Given this list of marker genes TRPC1, ATP2A2, SLC8A2, CORIN, GJA5, NKX2-5, ACE2, TBX5, EHD3, PRKACA, ATP2B2, TNNI3K, MIR19A, TMEM65, ATP2B4, SLC8A3, ATP2B1, AGT, RYR2, ATP2A3, MIR1-1, SLC8A1, ATP2B3, TRPM4, MIR208A, ANK2, GJD3, ATP2A1, here is a description of the gene set: species: Homo sapiens Any process that modulates the frequency, rate or extent of cardiac conduction. Human Gene Set: GOBP_REGULATION_OF_CARDIAC_CONDUCTION